The following is a description of a gene set: Human Gene Set: HP_GENERALIZED_ONSET_SEIZURE species: Homo sapiens A generalized-onset seizure is a type of seizure originating at some point within, and rapidly engaging, bilaterally distributed networks. The networks may include cortical and subcortical structures but not necessarily the entire cortex. Generalized-onset seizure, and this is the list of marker genes: SCN9A, MFSD8 (NCBI Gene Id 256471), PACS2, SETBP1, DMXL2, ATP6V0C, PIGH, PPFIBP1, HNRNPC, CASR, SLC6A19, MT-ND4, KARS1, ANO10, GABBR2, PRICKLE1, POGZ (pogo transposable element derived with ZNF domain), AARS1, GRIN2A, PIGT (phosphatidylinositol glycan anchor biosynthesis class T), DHDDS, NTNG1, GRIN2D, SETD1B, EIF4A2, EFHC1, GRIN1, MT-TL1, BUB1B, FAR1, PUM1, HNRNPK, CILK1, GRN, ASAH1, SLC25A12, LNPK, CACNA1H, MTHFR, SLC12A5, ARX (NCBI Gene Id 619216), MT-ATP6, KCNT1, SLC38A3, HCN2, ATP1A1, ZEB2, STX1B, SLC1A4, KCNH5, LONP1, RFX7, PRDM8, TUBB2B, SLC6A1, SRPX2, CDKL5, TSEN2, GNAO1, ZFX, NUS1, AFG3L2, RNF113A, PLAGL1, CIC, MAPK1, NDUFA1, ALDH4A1 (aldehyde dehydrogenase 4 family member A1), PIGP, SLC1A2 (solute carrier family 1 member 2), COG2, MT-TF, SMS, INS, EZH2, HYMAI, PRMT7, CAMK2A, RPL10, KCNJ11, STAT3, ALMS1, NTRK2, ELOVL4, NEDD4L, GABRA1, GPT2, NGLY1, CTNND2, SCARB2, MT-TS2, MARCHF6, KCNQ2, COQ8A (NCBI Gene Id 56997), ACSF3, UBE3A, MT-TI, SIK1 (salt inducible kinase 1), ERCC3, NECAP1, TRIT1, COQ5, CACNA2D1, DEPDC5, GJA8, ADRA2B, SCN2A, APOE, PRORP (NCBI Gene Id 9692), DPM2, COX8A, SZT2, MAPK8IP3, ABCC8, PGAP2 (post-GPI attachment to proteins 2), RNU4ATAC, SEPSECS, ATAD3A, SLC35A3, NHLRC1, CLN8, MEGF8, SCN1B, GABRG2, SYNGAP1, DHFR, FZR1, NFKB2, CACNB4, HCN1, DOHH, MTOR, CARS2, VPS53, CLCN2, SLC9A6, IER3IP1, EHMT1, GTF2E2, PLPBP, FBXL4, SCN8A, NADK2, MT-ND3, TMX2, DPM3, GPHN, MTR, PLP1, GLUD1, BCKDK, PEX2, ATP1A3, PIGA, GATAD2B, PAFAH1B1, TRIM8, SLC25A22, COL3A1, CACNA1A, PLAA, AP2M1, NUBPL, PTRH2, WDR26, WDR62, AFG2A, EXTL3, MT-ND6, MYCN, GCK, LGI1, CHD2, GABRB3, LMNB2, PCDH12, CNTNAP2, ADNP, TUBA1A, TBC1D24, GABRD, PCDH19, OSTM1, RARS2, NDUFA13, KCNQ3, PNKP, GAD1, MT-ND5, CEP85L, NARS1, GDI1, ADGRG1, TUBB3, YWHAG, IREB2, CAPRIN1, PPP3CA, AVPR2, TREX1, SDHB, MAPK10, OTUD7A, CAMTA1, DDX59, MYT1L (NCBI Gene Id 4662), KANSL1, WAC, ARHGEF9, GABRA5, MDH2, TARS1, ADPRS (ADP-ribosylserine hydrolase), CDK13, BRAT1, CPLX1, CLPB, BTD, RELN, CLCN4, NEU1, GBA1, SLC32A1 (solute carrier family 32 member 1), SEC31A, MPLKIP, CUX2, DNM1L, EPM2A, MT-ND1, SATB2, MT-RNR1, TSEN15, PTEN, NFU1, ALDH7A1, TBCD, GRM7, NBEA, LRPPRC, MT-TH, NEXMIF, MT-TW, HECW2, DPAGT1, TRMT10A, RAB11B, MT-ND2, SON, NDE1, KIF4A, PPP2CA, CRELD1, TSEN34, ACBD6, PCYT2, VPS50, ATXN10, GLUL, DCX, MAST3, TANGO2, PURA, FBXO28, SCN1A, APC2, PAK3, ZBTB18, RORB, PHGDH (phosphoglycerate dehydrogenase), SDHD, STXBP1, SMC1A, XK, MT-TK, CARS1, PRRT2 (NCBI Gene Id 81865), ALDH5A1, OPHN1 (oligophrenin 1), PSEN2, FGF13, YARS1, MT-TV, LAMA2, ERCC2, DYRK1A, AFF3, SUCLA2, ADGRV1, SATB1, CASK, PIGQ, KCNT2, TRAPPC9, GUCY1A1 (NCBI Gene Id 2982), ECM1, TSEN54, C1GALT1C1, FTL, HNRNPU, PIGM, SAMD12, DNM1, SMPD1, GJA5, PGAP1, FGFR3, RAI1, SLC25A15, GPAA1, NSD1, SLC4A10, AIFM1, FRRS1L, GLB1, WWOX, HACE1, KCTD7, MBOAT7, PIK3CD, TK2, KCNA1, SPTAN1, PMM2, GALC, DOCK7 (dedicator of cytokinesis 7), PIDD1, EXOC8, TRPM3, KCNJ10, SDHAF1, NAA10, MECP2, KCNB1, SLC2A1, MED13, KPTN (kaptin, actin binding protein), GNAI1, CSTB, KCNC2, PSAP, SDHA, YEATS2, GAMT, KNSTRN, CNTN2, GNB1, EEF1A2, PI4K2A, KCNMA1, GABRA3, GTF2H5, MT-TQ, SMARCA2 (NCBI Gene Id 95083), DPM1, PDX1, NEUROD2, GOSR2, CTCF, MT-TP, JRK, AFG2B